Given this list of marker genes Nop10, H3f3b, Brd7, Dpf1, Kifc5b, Pml, Ino80, Kpnb1, Hnrnpa2b1, Rb1, Kntc1, Cul3, Poldip2, Cdk2, Recql4, Smarca5, Ube2b, Mad1l1, Hspa1a, Rad51d, Hspa2, Dusp1, Xrcc3, Zfp207, Ruvbl1, Baz1b, Kash5, Ino80e, Knl1, Top1 (NCBI Gene Id 98994), Ndc80, Phf10, Bccip, Psrc1, Fbxw7, Sp100, Syce3, Anapc11, Becn1, Rnf212, Ercc4, Brip1, Norad, Smg6, Ncapd2, Ncapg, Chfr, Anapc1, Syce2, Riok2, Abraxas1, Rec8, Bmyc, Nvl, Clasp2, Anapc7, Zwilch, Ofd1, Mad2l1, Hhex, Aurkb, H1f4, Smc2, Naa50, Cit, Rrs1 (ribosome biogenesis regulator 1), Stag3, Banf2, Mcrs1, Abl1, Dkc1, Xpa, Mei4, Parp1, Hmgb3, Smarcc2, Nppc, Ankrd66, Nup133, Klf4, Terc, Dpf2 (NCBI Gene Id 78490), Top3b, Haspin, Dis3l2, Mapk15, Rad54l (RAD54 like (S. cerevisiae)), Shld2, Ccne2, Mterf1b, Psmc3ip, Vps4a (vacuolar protein sorting 4A), Actr8, Ten1, Fbxo30, Ppp2r1b, Nfrkb, Tex15, Sirt1, Brca2, Kif18b, Spata22, Ik, Ercc1, H1f10, Pkib, Dpf3, Pds5a, Tpx2, Sun1, Rab11a, Nipbl (NIPBL cohesin loading factor), Wrap73, Actl6a, Pelo, Gar1, Naa10, Arhgap33os, Chtf8, Arid2, Ctnnb1, Cdt1, Pcna, LTO1, Syce1, Yy1, Zwint, Spc24, Ppp2r5c, Gem, Prm3, Tnks2, Hmga2, Cenpk, Chmp7, Pogz, Smc6, Smarca2 (NCBI Gene Id 67155), Hdac8, Uchl5, Zfp827, Kif15, Prdm9, Cdca5, Plk1, Ska1, Nudt16, Mad2l1bp, Dscc1, Rad51, Bub1, Potefam3b, Zfp830, Ppp2r1a, Tfpt, Cpeb1, Wnt3a, Xrcc6, Nudc, Smchd1, Ripor2, Cdk5rap2, Hspa1b, Cct7, Dlgap5, Smc4, Bcl7a, Chmp2b (charged multivesicular body protein 2B), Chmp4b, Mapk3, Gen1, Map3k4, Nek6, Hmgb2, Hormad1, Bend2, Cip2a, Tpr, Chmp1a, Prpf4b, Ska3, Stn1, Stag2, Tcp1, Smc1b, Zfp365, Ino80c, Msh2, H1f5, Usp44, Kif2c, Anapc15-ps, Fbxo4, Kdm4a, Racgap1, Nabp2, Pbrm1, Nhp2, Ccdc61, Ccnb1ip1, Mta2, Cenpe, Smg5, Xrcc1, Spc25, Ncapg2, Tinf2, Msh5, Ndc1, Npr2, Ino80d, Ankrd31, H2al1a, Smarcd1, Top2a, Smarcb1, Cct8, Hmbox1, Pcid2, Ccnb1, Ago4, Apc, Mterf1a, Tex19.1, Ncaph, Map9, Zscan4d, Prap1, Gper1, Chmp1b2, Kif11 (kinesin family member 11), Top3a, Exosc10, Trp53, Cenpa, Nsmce2, Sugt1, Chek2, Mau2, Ankrd53, Mapre1, Map2k7, H1f0, Prkcq, Lsm14a, Esco1, Tent4b, Smc5, Msh3, Actr5, Upf1, Ncapd3, Pnkp, Cdc6, Spdl1 (NCBI Gene Id 76404), Hus1b, Ddx11, Macroh2a1, Anapc4, Dffb, Espl1, Cct6a, Cenpv, Mcph1, Xrn1, Tubg2, Ptges3-ps, Zmpste24, Kif23, Rae1, Incenp, Cenpi, H3f3a, Rangrf, Tert, Nup107, Kat2b, H1f7, Hsp90ab1, Champ1, Cenph, Esco2, Prc1, Tex12, Setmar, Ppp2r5d, Zscan4c, Mlh1, Cdca8, Terf2, Cdc27, Smc1a, Clasp1, Myc, Slx4, Chmp4c, Smarcd2, Eml4, Smg1, Mnd1, Sgo2b, Nek2, Ran, Cdc23, Banf1, Hus1, Shcbp1l, Aaas, Cenpo, Nbn, Top1mt, H1f2, Tal1, Slf1, Hormad2, Rif1, Chmp1b, Anapc5, Atf6b, Pibf1, Sycp3, Mei1, Bcl7b, Recql, Mis18a, Ccne1, 1700028K03Rik, Dclre1c, Tdrd3, Slf2, Numa1, Tacc3, Spo11, Eml3, Syde1, Bag6, Tcf7l2 (transcription factor 7 like 2, T cell specific, HMG box), Hmgb1, Parn, Ube2c, Slx1b, Lrrc34, Gch1 (GTP cyclohydrolase 1), Smarca4, Chmp2a, Smc3, Phf13, Katnb1, Gnl3, Cct4, Pds5b, Kif22, Atm, Nhej1, Lmna, Wrap53, Kif4, Ehmt2 (NCBI Gene Id 52041), Ube2u, Oip5, Nsl1, Atr, Nup62, Golga2, Misp, Itpa, Cdk1, Morc2b, Sfpq, Prickle1, H1f1 (NCBI Gene Id 80838), Fancd2, Pum2, Xrcc5, Lats1 (NCBI Gene Id 16798), Mapk1 (mitogen-activated protein kinase 1), Blm, Ercc3, Kif3b, Sgo1, Fbxo5, Hecw2 (HECT, C2 and WW domain containing E3 ubiquitin protein ligase 2), Mapkapk5, H1f3, Ccdc66, Cdc20, Cltc, Top2b, Pinx1, Mybl2, Shld3, Tep1, Cenpw, Ppp1r10, Anapc15, Kif18a, Ttk, Seh1l, Bnc1, Ldb1, Kif14, Bub1b, Terf1, Smarcd3, Dna2, Stag1, Actl6b, Rtel1, Meiob, Cdk11b, Ska2, Tnks, Arid1a, Dhx36, Prm2, Mos, H1f8, Sycp1, Mis12, Senp6, Vps4b, Nusap1, Iho1, Atrx, Cenpx, Shld1, Hjurp, Hnrnpd, Parp3, Fen1, Potefam3a, Pot1a, Nat10, Mcmdc2, Wrn (Werner syndrome RecQ like helicase), Khdc3, Mzt1, Ern2, Tex11, Dync1li1, Spdya (speedy/RINGO cell cycle regulator family, member A), Lig4, Birc5, Rnf212b, Chmp3, Kifc1, H1f9, Dcp2, Mcmbp, Prm1, Kat5, Sgo2a, Sirt7, Terb1, Rpa2, H2al2a, Prkdc, Mlh3, Akap8l, Rcc1, Acin1, Trip13, Topbp1, Nup155, Cenpc1, Suv39h1, Wapl, Cct3, Itgb3bp, Ppp1ca, Zw10, Meioc, Pot1b, Cenpn, Rad21l, Klhl22, Anapc2, Bcl7c (NCBI Gene Id 233901), Msh4, H1f6, Rhoa, Parp4, Fshr, Cep63, Sirt6, Pou5f1, Rad51c, Ctc1, Syce1l, Dclre1b, Map10, Cep192, Pttg1, Gtf2b, Mre11a, Lcmt1, Pif1, Wdhd1, Nasp, Cenpt, Tex14, Apex1, 4930447C04Rik, Shoc1, Rad50, Xrcc4, H2bc1, Cenpp, Meikin, Phb2, Terb2, Zcwpw1, Chmp5, Hnrnpc, Arhgef10, Zscan4f, Mael, Drg1, Cdc16, Snhg15, Axin2, Flna, Uhrf1, Ylpm1, Kif2a, Actb, Spag5, Smarcc1, Akap8, Cct5, Rpa1, Ccnb1-ps, Nup98, Hnrnpu, Hsp90aa1, Zbtb48, Smarce1, Knstrn, Abraxas2, Cep97, Rmi2, Dctn2, Spice1, Naf1, Acd, Cct2, Bub3, Chmp6, Rnf4, Rad21, Terf2ip, Tubg1, Nuf2, Ccsap, Mad2l2, Ruvbl2, Ino80b, Trappc12, Ncaph2, Psmg2, Ptges3, Nek7, Gnl3l, Src, Dmc1, Majin, here is a description of the gene set: species: Mus musculus A process that is carried out at the cellular level that results in the assembly, arrangement of constituent parts, or disassembly of chromosomes, structures composed of a very long molecule of DNA and associated proteins that carries hereditary information. This term covers covalent modifications at the molecular level as well as spatial relationships among the major components of a chromosome. Mouse Gene Set: GOBP_CHROMOSOME_ORGANIZATION